Given this list of marker genes ODAD4, AQP4, JHY, ODAD3, KATNIP, NHERF1, SPAG16, CFAP45, DNAAF3, DNAH9 (dynein axonemal heavy chain 9), DNAAF11, DAW1, CCDC39, CWH43 (cell wall biogenesis 43 C-terminal homolog), CFAP221, CFAP43, CFAP54, GMNC, here is a description of the gene set: Human Gene Set: GOBP_CEREBROSPINAL_FLUID_CIRCULATION studied in species Homo sapiens The neurological system process driven by motile cilia on ependymal cells of the brain by which cerebrospinal fluid circulates from the sites of secretion to the sites of absorption. In ventricular cavities, the flow is unidirectional and rostrocaudal, in subarachnoid spaces, the flow is multi-directional.